The following is a description of a gene set: Genes containing one or more binding sites for (POU2AF1) in their promoter regions (TSS -1000,+100 bp) as identified by GTRD version 20.06 ChIP-seq harmonization. Human Gene Set: POU2AF1_TARGET_GENES studied in species Homo sapiens from publication Yevshin I, Sharipov R, Kolmykov S, Kondrakhin Y, Kolpakov F (PMID 30445619), and this is the list of marker genes: FNDC11, METTL3, RNU6-2 (RNA, U6 small nuclear 2), MIR4434, IGKV2-29 (NCBI Gene Id 28920), EIF4G3, TRA2A, RUVBL1, DIAPH1, ZDHHC24, PRPF40A (NCBI Gene Id 55660), SDCCAG8, C2orf49-DT, PEX2, PTPA, ALDH1A1, CLCN3, HNRNPUL2, ANTXR2, IGLV3-25, SERF2, HNRNPUL1, SLC31A1, PLCXD1, NDUFS1, IGKV2-24, HSPA2-AS1, SLC30A4-AS1, AKAP7, TAF15, NECAP2, PHC2, SOX11, C12orf57, KCTD6, ID2, CCNG2, OR1F2P, GABPB1-AS1, LRRC56, RNF115, TRMT44, H2BC12, U2AF2, SNX5, MAFA, ATF6, NOP2, CSF1R, RPL28, TAF10, ZNF251, CYCSP38, CEACAM1, TMEM199, TMEM255B, NUTF2, SDC3, ZFAS1, IGKV2D-29, MAPKBP1, MIR5700, ADRM1, CHKB-DT, PFN2, ZNF138, STX12, BTRC, ALDOA, QPCTL, KRBA2, SINHCAF (NCBI Gene Id 58516), SNRPE, ARPC5, PORCN, NLGN2, IGLV3-9, LNCRNA-IUR, LINC02863, DLG3, PPP3CB, H2BC16P, ERCC4, REXO1, RNU6-319P, TUBB4A, GRWD1, SH2B1, C15orf62, SEMA6C, OTUD5, CDC27, BHLHE40-AS1, CROCC, LENG9, SOX1, CRACR2B, RFXAP, H2BC3, PSD4, ZBTB33, C1QTNF6, CHD6, KDM3A, SLC7A7, NXT2, TAF6, CASC15, TRAK1, ABRAXAS1P1, RPL22, LAMC1, RPL30P11, LRRC71, PRMT3 (NCBI Gene Id 10196), SRP19, BHLHE40, DESI1, ZNHIT2, NOL9, IGKV2D-40, DYRK1B (NCBI Gene Id 9149), ENDOU, IGLV11-55, IGLV3-10, CFAP36, EGLN2, ACBD4, HTATSF1P2, IGLV1-40, EEF1B2, MIR30A, CFAP276, MIR6853, IGHV4-59, TP53RK, PDCD10, PLEC (NCBI Gene Id 5339), ANKRD13A, TLCD3B, DDX27, SDHB, UBE2T, TEDC2-AS1, LRP6, MIGA2, IGKV2D-28, IGHV5-51, CNNM4 (cyclin and CBS domain divalent metal cation transport mediator 4), CRYZL1 (crystallin zeta like 1), LENG8-AS1, AKAP9, CD81, CALM2, IGLV7-43, PPP2R1A, SWT1, LRCH4, CBFA2T3 (CBFA2/RUNX1 partner transcriptional co-repressor 3), PPP3CB-AS1, DLGAP5, IGLV4-69, IMP3, G6PC3, H2BC8 (H2B clustered histone 8), WEE1, PGD, TOPORS, EIF4ENIF1, HSPA2, IGLV5-45, FOXO3, HLA-DRA, ARID5B, KCNMA1-AS1, PAQR4, BCL2L1, RFX1, TEN1, AMZ2, BABAM1, DLEU1, GAPDH-DT, TSEN34, RAB26, IGLV3-19, SS18, KCTD9, ENSG00000272384, MIR142HG, ZNF568, ENKUR, E2F3, TRAPPC8, FARS2, SDE2, HPS4, CDCA7, MIR3143, SPAG6, TIPIN, H2BC5, ZNF671, C16orf54, HRAS, ATF6-DT, PIK3R2, RABGAP1L, LENG8, CARF, RNU11, XPO1, RIN1, ACTN3, APH1A, IGKV2OR2-2, RAVER1, ISYNA1, ELF1, ZNF225-AS1, MYOSLID-AS1, GTPBP1, TXNL1, RMRP, WDR12, OPN3, PAN3, GSK3B-DT, ZNF564, DIP2C, TCAF1, ENSG00000227218, HAPSTR1, NAP1L4, SFSWAP, ARL5A (NCBI Gene Id 26225), ZNF559 (zinc finger protein 559), OSBPL10-AS1, ZAR1L, QSOX2, GARNL3, GRAMD1B, DLEU2 (deleted in lymphocytic leukemia 2), LINC03034, AXIN2, NFASC, ZSCAN5A, NXT1, PPP1R11, RN7SKP34, VIM-AS1, TIPARP, CHKB, IGLV8-61 (NCBI Gene Id 28774), SAMD4A, PANK4, KANSL1L, GGCX, CHD9, MCEMP1, HDAC11-AS1 (HDAC11 antisense RNA 1), DCXR-DT, BANK1, NEU1, ELAPOR1, RNU6-8, STRIP1, MFF, WDR74, PRRC2A, IGLV3-6, WDR5B, H2BC21, GOLGA7, DZANK1, INTS10, STX1A, NME1, ST18, DOK3, USP30, ZNF655 (zinc finger protein 655), RHOH, LZTFL1, IGKV2D-30, DOCK11, ZNF428, CDK14, LDLRAD4, C2orf49, EBAG9, FGD4, CD79B, RPL17P15 (ribosomal protein L17 pseudogene 15), MGRN1, GADD45G, ZNF766, MCUR1, DIPK2A, PLGRKT, HMGA1, MAP4K1, CABLES2, SREBF2, FCHO1, RPL27, MTF2, CFAP418-AS1, SLC25A25, ENSG00000269151, LINC01232, ROGDI, CROCCP3, H2BC7, CYFIP2, CHKB-CPT1B, ELL, LRIG2, NALT1, CENPU, SRF, TBC1D16, ZNF585B, BCL2L12, AMPD3, ZNF273, PTGES2, TTI2, KAT7, TMEM238, SGO2, GAPDH, DBNDD1, ADAM15, DPYSL2, IER3, ARHGAP25, RDH11, EBF1, MRPL46, H2BC10, IGHV2-26, IWS1, WAC-AS1, IGKV2D-24, LINC01248, KLF13, FBXO46, IGKV1-8, ENSG00000253214, UFD1, FXR1, PFKFB3, RN7SKP249, VPREB1, TMC6, YWHAE, PKMYT1, ARGLU1, RALGPS1, IGHV5-78, ATP2B4, ZNF100, CENPT, PPFIA3, IGLV3-22, IGLV5-48, IGHV3-37, AKNA, CEP170, SERPINI1, ITSN1, BTBD3, RRAS, SNORD118, GSK3B, TEX41, HIPK1, CAP2, ZNF184, TTC9C, MAST3, SMAD4, FAM13C, RNU5E-4P, SCAMP1, SRSF1, CASP5, IGKV2D-18, GLS, ERP27, GTPBP6, RN7SKP240, SHROOM3, TOM1, AFG2A, FBXO24, FAM76A, PRAME, GTPBP3, N4BP2, THAP1, RAB4B-EGLN2, RNU7-1, SERTAD1, NSMF, IGKV3-20, LINC01122, RPS26, LTA4H, CREB3, EXOSC3, RNU6-7, TCF4, NFE2L1, SH3BP1, ZNF724, KCNAB2, H2AC8, NMT1, BRPF1, MEAK7, CTNNBIP1, PHF5A, CCNI, RN7SL784P (NCBI Gene Id 106481134), IGKV2-10 (NCBI Gene Id 28928), AJUBA, IKBIP, ARHGEF37, UMODL1, MSH6, GYS1, RNU5E-1, H2AC10P, FAF2, ZNF430, DOP1A, ZNF589, HDAC9, MYLK, DHPS, MRPS11, H3C7, RNU6-9, FOXN3, VIM, RNF135, CENPJ, ECE1, PTPN9 (protein tyrosine phosphatase non-receptor type 9), IGLL5, RNF44, MYO1C, TRMT1L, ADNP, RNF43, EPN2-AS1, DAG1, NAB2, CKLF, NPHP4, IGLV2-8, AGRN, FZD1, SSBP1, PHC2-AS1, PMAIP1, IGLL1, SIRT4, LINC00881, KIF18B-DT (NCBI Gene Id 118827817), SLC20A2, TP53RK-DT, EFNA3, ESRRA, LNCATV, LIN54 (NCBI Gene Id 132660), IGLV4-60, ANKRD13D, PRDX5, BTD, MIR4513, RNU5E-6P, RSPH14, RN7SKP165, IQCF3, IGKV2-14 (NCBI Gene Id 28927), SH3BGRL, TBC1D22A-DT, PHTF2, KIF15, H2BC9 (H2B clustered histone 9), HACL1, NOTCH1, ABTB2, PHF8, CD37, CNPY4, USP8, ZNF197, TRMT112, ANKS1B, CDV3, TGIF1, TG, USP13, ESR2, EIF4H, DLG4, RNU4-86P, HNRNPUL2-BSCL2, SORBS2, MIR4674, FBXO16, ATXN2L (ataxin 2 like), MAD2L2, GALNT10, LINC02926, TIMP2, SPATS2L, RASSF10, ACKR4, MIR3142HG, TSC22D3, KIF18B, TCF12, NDUFAF1, LRIG1, APAF1, H2AC5P, ARL6IP6, TRD-AS1, NFIA, ACOX1, ZNF680, ARHGAP26, WEE2-AS1, POLR3C, CLIC4, TIAM1, IRF2BP1, KPTN, GNA15-DT, TNFRSF18, BEGAIN, ZNF780B, IGKV1D-8, AP3S2, RGS20, IGHV1-69, RNU5A-1, ZNF839 (zinc finger protein 839), LINC02920, VAMP8, GSE1, TMEM259, LINC00426, SMC6, SLC2A14, YTHDF2, PLCB4, NEMP1, FKBPL, DICER1, PTGES2-AS1, TAF4, CDR2L, ZSCAN5A-AS1, TMEM39B, MDM4, LINC01483, COPS7A, LINC00910, TLR9, IGKV1-39, ESYT1, ANK1, RNU5B-1, H3-3B, SNORD13, MIR5195, IGLV6-57 (NCBI Gene Id 28778), RHBDF2, FDFT1, APOLD1, FBXL19-AS1, TIPARP-AS1, CACNA1A, RUVBL2, IGLV3-16, MARK2, ACO2, RNU6-669P, PTOV1, FAM168A, NINJ2-AS1, MFF-DT, STMN3, FAM215A, PSMC2, IGKV2OR2-1 (NCBI Gene Id 28861), ZNF829, BEND3, C1R, ZFYVE1, NUP62, IGFBP7, RPL13, ESPNL, HDAC11, TARDBP, SREBF1, SEMA6D (semaphorin 6D), TSPAN32, NT5C, TMSB4X, NAPA-AS1, ANXA3, SLC39A8, TSPAN13, CDC45, NME1-NME2, NRGN-AS1, RNF187, KDM1A (NCBI Gene Id 23028), H2AC20, UGP2, KLF10, KBTBD6-DT (NCBI Gene Id 101929140), THAP11, MIR3945, MIR4425, SNX1, CSTF2T, HMGN5, H3C12, ATP1A3, H2BC18, H2AC21, KAT6A, ASPHD2, IGHV3-48, IGHV1-69D, DCTD, ATG16L2, NECAP1, BRD2, DAAM1, MED16, GINS1, EPCIP-AS1, ZNF20, C14orf119 (chromosome 14 open reading frame 119), CSNK1A1, MICALL1, BRCA2, DLL3, MTA2, PNPLA8, HSPH1, LRRC8D, INPP5D, IFRD1, ALDH3B2, ZFYVE26, MAP6D1, FAM98A, TMEM62, IGLV3-27, RAB4B, CDK16, IPCEF1, RBL1, CEP128, NPAS1, ZBTB45, TMEM33 (NCBI Gene Id 55161), DGKA, DEAF1, FAM117A, ACIN1, USO1, DPP9, TLCD1, HS3ST3B1, EGR2, PNKD, FBXL19, MOB3A, ARHGEF7, GEN1, CHML, TRAF3IP2, FADS3, ARB2A, SLEAR, HEXIM1, ENSG00000267568, BUB1, H2BC4, SLC44A1, AAMP, RSL24D1, H2AC7, MIR5189, ITGA4, HARBI1, MIR634, RNU2-2P, IGHV3-66, EFNA5, POU2AF1, RBM4, CMC2 (C-X9-C motif containing 2), SNRPD2, ENSG00000239142, SNORD68, GSPT1, KIFAP3, ZNF383, INTS6L-AS1, MBOAT7, MEF2C, COQ8A, HEXB, RUNX1, AOX1, ADGRL1, POU2F3, ZFP3-DT, KBTBD6 (NCBI Gene Id 89890), IGLV5-52, TTLL6, ZNF22-AS1, TTBK1, ATF7IP, ZNF423, H2BC17, NAIF1, EIF3K, MICU2, PCNX2, SRRT, SESN3, CCDC28B, TK2, EEIG2, SPRY1, BCL9, ELL3, SPAG8, PFKFB4, SLC27A2, TAS1R1, HSF2, CASP7, LINC02202, ATG13, H2AC16, IGHV4-34, ZC3H12D, CCDC107, TMEM256-PLSCR3, FAM200A, FKBP5, IGKV2-28, DPH1, APBA1, OPA3, IGKV2-18, SMAD2 (SMAD family member 2), ETV5, ATAD2 (ATPase family AAA domain containing 2), RAPGEF6, IRAG2, RPS6KA4, CNTRL, IFT140, CLTC, SGK1, LINC01562, BLNK, IGKV2D-10, BAZ2A, NHSL1, PLCB1, LINC02938, COL9A3, STX6, XXYLT1, ABCC10, WDR7, MIR3680-1, SBNO2 (strawberry notch homolog 2), GFOD1, POLDIP2, PCDH12, ZNF443, PRDM2, LL22NC03-63E9.3, IGKV2-30, TMEM80, NCR3, ST6GAL1, PLCB3, ABTB3, KCNN3, SH2D3C, ZNF559-ZNF177, STAG3L5P-PVRIG2P-PILRB, SYVN1, PIM2, LIMD2, CIC, IGLVI-70, P2RY8, G3BP2, IGLV1-47 (NCBI Gene Id 28822), DNAJC2, ASXL1, ADNP2, LINC02427, GADD45A, JARID2, RNU4-2, NAA16, TMC8, ENC1, POU2F1, H2BC14, ZNF225, PRKCI, CNN3, ABR-AS1, OXR1, PAXBP1, PSAT1, PCM1, NFYC (nuclear transcription factor Y subunit gamma), LRPPRC, MZB1, LINC01993, RPPH1, DCXR, IER5L, RAB29, POLM, VPREB3, DPM2, STAG3L5P, TRERF1, AMER1, AKT2, UST-AS2, MAPK1, REL, LMAN2L, LIX1L, AKR1C3, NEK11, PARP2, PLEKHM1P1, MID1IP1, PTPN7, ZSWIM6, ID3, DAPK3, ZFAND5, PRXL2B, HMX2, SLC38A2, DUSP10, ENSG00000226281, UQCC2, RPRD1A, MTERF1, TOP1, MEMO1 (NCBI Gene Id 63983), IMPDH2, IRF3, FKBP15, KMT2D (NCBI Gene Id 8085), IGLV1-36 (NCBI Gene Id 28826), H2AC11, PIGK, NRIP1, TBC1D22A, ATP5MGP3, AK5, IGKV1OR2-108, ADAMTS6, ZNF700, TMEM37, HIVEP2, NEDD9, H2AC6, AP1G1 (NCBI Gene Id 164), SYTL3, RNU2-4P, CKLF-CMTM1, IL4I1, DYNC2I1, CDCA2, IGKV3-11, BLCAP, CPD, LINC02960, CENPN, TSPAN3, TMEM256, H2AC17, OCEL1, INTS6L, LYRM4, HMGN1P26, WAC, PPP1R14A, NFYC-AS1, RAPGEF3, UBE2S, TLN1, H2AC14, PLEKHG2, CD72, H2AC4, IGKV1OR2-6, TYMS, IGHV3-53, TP53INP2, NUDT6, SLC39A13, H2AC12 (H2A clustered histone 12), CREB1, H2BC11, KIAA1143, RABEP2, TRIOBP, MEF2B, EXOC1, LYN